Given this list of marker genes GCHFR, AP1S2, PDLIM1, IGFBP4, SLC26A2, AMIGO2, RHOBTB3 (Rho related BTB domain containing 3, NCBI Gene Id 22836), STC1, TMCO6, PABPC1L, PIK3R1, FGFBP2, MTFP1 (NCBI Gene Id 53596), NAB2, TOP2A, HCFC1, FCMR, HNMT, HPCAL1, MGP, LETM2, SIAH2-AS1, IGSF1, SCARB1, UNC13C, RBM33, TST, NSUN5P1, CADM1, KDM4B, MPPED2, RBBP8, DUXAP8, SYTL4, CD44, TTC39A, ESR1, PIKFYVE, POLR1D, GFRA1, IRX5, COX6CP1, LINC00992, TFAP2C, MAPT, RERG, CXCL12, SFXN2, PTGR1, COL4A5, FREM2, LARGE1, NREP, E2F4, HPGD, SEMA4C, GREB1, IL27RA, LONRF2, ATP11A, TNNT1, ZSWIM6, SH3BP5, EFNB3, ADAMTS19, PLAC1, MAP2, IGF1R, PSMG1, ATP2B4, SYBU, SNTG2-AS1, PARP4, FAXDC2, COL5A1, FLNB, TOP1MT, CTPS2, GPER1, BOD1, RNF167, TMPRSS3, MOCS2, FRK, ARHGAP36, LRIG1, HR, DARS1, PDCD4, ADAMTS15, PLIN5, TPD52L1, SH3BGR, ZNF385B, MBOAT7, SOX3, CRABP1, MYBL1, TUBB2B, TMT1B, AFAP1L2 (actin filament associated protein 1 like 2), LINC00408, SIAH2, SUSD4, FADS3, PDZK1, CBX2, DOK7, IRX3, SRI, KLF10, PYCARD, FYB2, SAMD15, ZHX2, WASF1, APBB2, LAGE3, TSKU, GTF3C2-AS1, TMA16 (translation machinery associated 16 homolog), HIP1, PRSS23, RAB31, IL17RB, AMFR, FZD1, GNB4, DUBR, MREG, SLC1A4, SYT12, ELOVL2, DUSP2, RHOBTB1, SOX4, ARL3, OLFM1, ATRNL1, FGFRL1, KCNJ3 (potassium inwardly rectifying channel subfamily J member 3, NCBI Gene Id 3760), ELP2, ARMT1, SLC39A6, SUSD3, MAGED4B, MT2A, PNPLA3, PPM1K, RMST, ADD3, ADCK2, LINC01968, FRAS1, AHSA2P, NPY1R, TSPYL2, NRIP1, THSD4, NEIL2, BMPER, ANXA6, CCNA1, DDAH1, FOXO3, H19, NPY5R, TIAM1, SYT1 (synaptotagmin 1), BCL2, PMAIP1, ZBTB10, TEAD1, DEPTOR, TMEM164, ELOVL5, LAMP2, TPBG, RAB11FIP3, PPP1R26-AS1, SGK3, KDM1B, TUBB6, ZNRF2, TCN1, TIPARP, DLG5, CUX1, CCNB1, HOXC10, S100A7, ZNRD2, SERPINA5, CPE, RBM24 (RNA binding motif protein 24), PRLR, MYB, ADRA2A, BLVRA, CA12, PRAG1, STARD13, PGR, ST8SIA4, MYO16, MIR503HG, TMPRSS4, RHBDF2, RXRA, NT5C, NRCAM, CALB2, GLA, IL20, CELSR2, CISH, SCD5, LMNB1, CBX5, MYOF, HNRNPA0 (heterogeneous nuclear ribonucleoprotein A0), SMPDL3B (NCBI Gene Id 27293), CCNG1, GPR173, NPNT, NBPF1, NAV1, DLC1, PTPRG, PKIB, RPL13P5, C1orf226, RNF183, EGR3, KANSL1-AS1, IRS1, NMRK1, MAP3K12, COPS9, SUPT3H, APTX, ABAT (NCBI Gene Id 731754), FKBP5, DSCAM, CDV3, ISOC1, ADCY9, KAZN, SLC22A5, MEGF9, ETNK2, NSUN5, ZNF703, AREG, PARD6B, here is a description of the gene set: Human Gene Set: MASSARWEH_TAMOXIFEN_RESISTANCE_DN Not all breast cancers respond to tamoxifen, and many develop resistance despite initial benefit. We used an in vivo model of estrogen receptor (ER)-positive breast cancer (MCF-7 xenografts) to investigate mechanisms of this resistance and develop strategies to circumvent it. Epidermal growth factor receptor (EGFR) and HER2, which were barely detected in control estrogen-treated tumors, increased slightly with tamoxifen and were markedly increased when tumors became resistant. Gefitinib, which inhibits EGFR/HER2, improved the antitumor effect of tamoxifen and delayed acquired resistance, but had no effect on estrogen-stimulated growth. Phosphorylated levels of p42/44 and p38 mitogen-activated protein kinases (both downstream of EGFR/HER2) were increased in the tamoxifen-resistant tumors and were suppressed by gefitinib. There was no apparent increase in phosphorylated AKT (also downstream of EGFR/HER2) in resistant tumors, but it was nonetheless suppressed by gefitinib. Phosphorylated insulin-like growth factor-IR (IGF-IR), which can interact with both EGFR and membrane ER, was elevated in the tamoxifen-resistant tumors compared with the sensitive group. However, ER-regulated gene products, including total IGF-IR itself and progesterone receptor, remained suppressed even at the time of acquired resistance. Tamoxifen's antagonism of classic ER genomic function was retained in these resistant tumors and even in tumors that overexpress HER2 (MCF-7 HER2/18) and are de novo tamoxifen-resistant. In conclusion, EGFR/HER2 may mediate tamoxifen resistance in ER-positive breast cancer despite continued suppression of ER genomic function by tamoxifen. IGF-IR expression remains dependent on ER but is activated in the tamoxifen-resistant tumors. This study provides a rationale to combine HER inhibitors with tamoxifen in clinical studies, even in tumors that do not initially overexpress EGFR/HER2. species: Homo sapiens Genes down-regulated in breast cancer tumors (formed by MCF-7 xenografts) resistant to tamoxifen. from publication Massarweh S, Osborne CK, Creighton CJ, Qin L, Tsimelzon A, Huang S, Weiss H, Rimawi M, Schiff R (PMID 18245484)